The following is a description of a gene set: A decreased concentration of insulin in the blood. Hypoinsulinemia studied in species Homo sapiens Human Gene Set: HP_HYPOINSULINEMIA, and this is the list of marker genes: CEL, NEUROD1, PCSK1, ZFP57, ABCC8, PDX1, INS, PAX4, KCNJ11, HNF4A, KLF11, AKT2 (AKT serine/threonine kinase 2), DMXL2 (Dmx like 2), APPL1, BLK, STAT6, PLAGL1, RNF125, HYMAI (NCBI Gene Id 651977), NAB2, GCK, HNF1A